Given this list of marker genes ZNF565, SIRT7, MRPS16, CALCOCO2, SNN, COQ8B, MYADM, LRRC14, MYOF, STX12, SDHC, TSPAN14, TCAF1, POC1A, GLUL, C1orf74, CLYBL, RUNX3, PATZ1 (POZ/BTB and AT hook containing zinc finger 1), SPATA2, USP12, VIM, CDC25A, OTUB1, ICMT, TMEM243, LRRN1, PSMB9, MIF, CCSER2, IRF8, PAFAH1B2, CPNE3, OGFOD2 (NCBI Gene Id 79676), MLLT1, TMEM70, HJURP, DDX31, MED22, ELF2, UBQLN1, RTN4RL1 (reticulon 4 receptor like 1), FAM98B, C10orf120, MYEF2, E2F2, TUBGCP5, HMGXB3, UBE3B, RRP36, NEK7, ZNF217, PPP1R37, TRIR, LDB1, PAFAH1B1, TRPC4AP, TLK2, STX6, SMDT1, ACTR2, GAN (NCBI Gene Id 8139), BBS2, GANAB, ZNF574, REX1BD, PTPA, APOBR, NEK2, PALD1, KCTD14, C11orf24, RNF31, CSNK1G2, STUB1, FAM219B, ARRB1, TAF6, MED11, MAVS, VRK2, SNX9, KCNMB4, TMEM108, AKNA, SLC5A6, NRROS, SLC29A3, FOXRED2, RRAGC, HOXA3, LAMP2, HMCES, BSDC1, ZNG1B, HOOK2, ZNRD2, MRPL34, TACC3, UXS1, CAPN15, ABL2, MINDY4, KLRD1, FBRS, GNG2, MAP7D1, SPNS3, USP37, UBE2N, NDUFA11, PAGR1, MINDY3, GID4, WIPI2, ZDHHC13, TAF5L, MFHAS1, CTSS, LETM1, RPLP0, COX10, STX1A, SLC25A22, ATP5F1E, FBXW8, AP4M1, YEATS4, PADI2, RNF123, FAM174C, PSME1, BANK1, ENO1, ZBTB7A, LIPT2 (lipoyl(octanoyl) transferase 2), IL31RA, RND3, CD79B, MEPCE, RAMP1, ITPR3, CHMP1A, TRAF3, ATF6B, LIMD1 (LIM domain containing 1), FPGS, PSAP, MIIP, HS6ST1, UNC93B1 (unc-93 homolog B1, TLR signaling regulator), LMNTD2, MAPKAPK5, MTA2, GUCA2A, COPG1, GSTK1, PPP1R12C, APBA3, PIGF, CC2D1B, NONO, SAPCD2, HES6, FXYD7, AIP, TIMM8B, NEDD8, LGR5, H2AZ1, GBA2, UBD, RNF40, RAB35, CD2AP, ANKRD40, ARHGAP9, UBE2S, GPN3, ATPAF2, SWI5, DENND1C, RCN2, ARHGAP45, TMEM9, CCDC59, RHOH, ATP6V0B, PHRF1, NOL8, ACVR1B, UBOX5 (U-box domain containing 5), GM2A, REEP1, DNAJC17, CCND1, PPHLN1, TAF8, HNRNPH1, MPLKIP, here is a description of the gene set: C57Bl/6 wild-type and STAT6 KO mice were used to study PPARg and IL-4 signaling. Bone marrow of 3 mice per group was isolated and differentiated to macrophages with M-CSF (20 ng/ml). 20 ng/ml IL-4 was used to induce alternative macrophage activation and 1 uM Rosiglitazone (RSG) was used to activate PPARg. From each mouse 4 samples were generated: 1. M-CSF, 2. M-CSF+RSG, 3. IL-4 and 4. IL-4+RSG. All compounds were added throughout the whole differentiation process, and frech media was added every other day. Control cells were treated with vehicle (DMSO:ethanol). After 10 days, RNA was isolated and gene expression profiles were analyzed using Mouse Genome 430 2.0 microarrays from Affymetrix. from publication Szanto A, Balint BL, Nagy ZS, Barta E, Dezso B, Pap A, Szeles L, Poliska S, Oros M, Evans RM, Barak Y, Schwabe J, Nagy L (PMID 21093321) species: Homo sapiens Human Gene Set: GSE25088_CTRL_VS_ROSIGLITAZONE_STIM_STAT6_KO_MACROPHAGE_DN Genes down-regulated in bone marrow-derived macrophages with STAT6 knockout: control versus treated with rosiglitazone.